The following is a description of a gene set: Mouse Gene Set: MIR_744_3P from publication Chen Y, Wang X (PMID 31504780) Genes predicted to be targets of miRBase v22 microRNA mmu_miR_744_3p in miRDB v6.0 with MirTarget v4 prediction scores > 80 (high confidence targets). studied in species Mus musculus, and this is the list of marker genes: Clec16a, Ptpn5, Rbm39 (NCBI Gene Id 97038), Cptp, Manea, Epm2aip1, Rad23b, Ppp1r14bl, Kdm6a, Ppp2r1b, Foxa1, Osbpl9, Nufip2, Galnt6, Tmem140, Bclaf1, Kctd4, Ikzf3, Stradb, Endou (endonuclease, polyU-specific), Fmr1, Fzd5, Azin1, Slc16a2, Apbb2, Ubox5, Il18bp, Mfsd14b, Cstf2, Usp30